The following is a description of a gene set: part of: Metabolism of nucleotides studied in species Homo sapiens Reactome Pathway: Nucleotide biosynthesis The purine ribonucleotide inosine 5'-monophosphate (IMP) is assembled on 5-phospho-alpha-D-ribose 1-diphosphate (PRPP), with atoms derived from aspartate, glutamine, glycine, N10-formyl-tetrahydrofolate, and carbon dioxide. Although several of the individual reactions in this sequence are reversible, as indicated by the double-headed arrows in the diagram, other irreversible steps drive the pathway in the direction of IMP synthesis in the normal cell. All of these reactions are thus annotated here only in the direction of IMP synthesis. Guanosine 5'-monophosphate (GMP) and adenosine 5'-monophosphate (AMP) are synthesized from IMP (Zalkin & Dixon 1992).<p>The pyrimidine orotate (orotic acid) is synthesized in a sequence of four reactions, deriving its atoms from glutamine, bicarbonate, and aspartate. A single multifunctional cytosolic enzyme catalyzes the first three of these reactions, while the last one is catalyzed by an enzyme associated with the inner mitochondrial membrane. In two further reactions, catalyzed by a bifunctional cytosolic enzyme, orotate reacts with 1-phosphoribosyl 5-pyrophosphate (PRPP) to yield orotidine 5'-monophosphate, which is decarboxylated to yield uridine 5'-monophosphate (UMP). While several individual reactions in this pathway are reversible, other irreversible reactions drive the pathway in the direction of UMP biosynthesis in the normal cell. All reactions are thus annotated here only in the forward direction.<p>This pathway has been most extensively analyzed at the genetic and biochemical level in hamster cell lines. All three enzymes have also been purified from human sources, however, and the key features of these reactions have been confirmed from studies of this human material.<p>All other pyrimidines are synthesized from UMP. The reactions annotated here, catalyzed by dCMP deaminase and dUTP diphosphatase yield dUMP, which in turn is converted to TMP by thymidylate synthase., and this is the list of marker genes: ADSS1, GART, UMPS, ADSL, PPAT, IMPDH1, IMPDH2, CAD, PFAS, ATIC, PAICS, ADSS2, GMPS, DHODH